Given this list of marker genes Stra8, Pecam1, Nr0b1, Tbx3, Zfp42, Esrrb, Dazl, Piwil2 (piwi-like RNA-mediated gene silencing 2), here is a description of the gene set: studied in species Mus musculus Genes down-regulated in mES cells (mouse embryonic stem cells) after tratment with JAK inhibitor I. Mouse Gene Set: TESAR_JAK_TARGETS_MOUSE_ES_D3_DN from publication Tesar PJ, Chenoweth JG, Brook FA, Davies TJ, Evans EP, Mack DL, Gardner RL, McKay RD (PMID 17597760) The application of human embryonic stem (ES) cells in medicine and biology has an inherent reliance on understanding the starting cell population. Human ES cells differ from mouse ES cells and the specific embryonic origin of both cell types is unclear. Previous work suggested that mouse ES cells could only be obtained from the embryo before implantation in the uterus. Here we show that cell lines can be derived from the epiblast, a tissue of the post-implantation embryo that generates the embryo proper. These cells, which we refer to as EpiSCs (post-implantation epiblast-derived stem cells), express transcription factors known to regulate pluripotency, maintain their genomic integrity, and robustly differentiate into the major somatic cell types as well as primordial germ cells. The EpiSC lines are distinct from mouse ES cells in their epigenetic state and the signals controlling their differentiation. Furthermore, EpiSC and human ES cells share patterns of gene expression and signalling responses that normally function in the epiblast. These results show that epiblast cells can be maintained as stable cell lines and interrogated to understand how pluripotent cells generate distinct fates during early development.